The following is a description of a gene set: Human Gene Set: GOBP_PROTEIN_HYDROXYLATION The addition of a hydroxy group to a protein amino acid. species: Homo sapiens, and this is the list of marker genes: P3H3, PLOD3, OGFOD1, P3H1, P3H4, VIPAS39, EGLN2, EGLN3, JMJD4, JMJD6, PLOD2, P4HB, JMJD7, PLOD1, P3H2, VPS33B (NCBI Gene Id 55513)